The following is a description of a gene set: Abnormal upper limb bone morphology studied in species Homo sapiens Human Gene Set: HP_ABNORMAL_UPPER_LIMB_BONE_MORPHOLOGY, and this is the list of marker genes: CLIP2, BRIP1, TRPV4, AGPS, FGF10, FBXO11, TBX5, BRAF, PCYT1A, RRAS, COL1A1, RFWD3, CCNQ, ATL3, TNFRSF11A, KAT6B, LZTR1, GPX4, CSPP1 (centrosome and spindle pole associated protein 1), H3-3B, MAN2C1, RASA2, RUNX2, ASAH1, SKI, RSPO2, CLCN7, IFT52, SMAD6, FMR1, RPS19, AMMECR1, KRAS, B3GALT6, GNAS-AS1, TPM2, EOGT, COLEC11, HS2ST1, FLNB, MACROH2A1, EP300, PACS1, DHODH, CHST3, COL5A1, SNRPB, DNAJC30, MEIS2, CPLX1, MKKS, APC, AFF4, COL3A1, IFIH1, MED12, KIAA0753 (KIAA0753), LAMA5, WDR19, SUZ12, MAP2K2, ALG12, BAZ1B, SVBP, DYNC2H1, KIF7, SIAH1, TRPM3, SETBP1, PRKD1, KCTD1, MAP3K7, PIK3CD, PPOX, TWIST1, EXTL3, GNPNAT1, CILK1, FANCM, PALB2, RAD21, DHX30, CLDN16, SLC39A13, RAB23, BMP6, NDN, POLR3A, ARHGAP31, SOS1, SLC26A2, MTX2, IFT140, POGZ, NALCN, PRG4, RLIM, TBL2 (transducin beta like 2), FAT4, PHYH, MMP14, ERCC4, HFE, BHLHA9, SNIP1, RAB3GAP2, CHRNG, MAFB, GLB1, TCTN3, MMP13, TNFRSF11B, TCF12, DNM1L, COG4, PCNT, RIPK4 (receptor interacting serine/threonine kinase 4), OFD1, LIG4, SNRPN, NHS, RRAS2, KIAA0586, ZIC3, RSPRY1, GLI3, EIF4A3, MEGF8, DVL3, CYP26B1, KCNJ2, EXOC6B, POR, KIF22, CPLANE1, PCDHGC4, EIF4H, SATB2, PTCH1, KNSTRN, FANCG, GATA4, USP9X, COL2A1, CHN1, SCN9A, NRAS, JAG1, DHCR7, DCHS1, SIL1, ARID1B, BANF1, STX1A, FZD2, G6PC3, TOMM7, BMPR1B (bone morphogenetic protein receptor type 1B), HOXA11, XYLT1, RFC2, ADAMTS10 (NCBI Gene Id 81794), EXOSC2, RBM10, MATN3, ANKRD55, TMEM270, FERMT1, PTPN2, GJA5, PDE3A, TBX15, FIG4, AGA, FGF16, CLCN3, RAF1, SRCAP, SALL4, MAP2K1, P3H1, SMARCA2, CSGALNACT1, HOXD13 (homeobox D13), MECOM, CTBP1, FANCE, ROBO1, BMPR1A, NFIX, STX16, SHH, LONP1, IFT80, COLEC10, COL11A2, BPTF, INPPL1, AFF3, GPC3, LRP5, COL10A1, ERI1, COL9A1, ZNF141, SF3B4, RIT1, PIGT, RBPJ, MTHFS, FANCC, TRPS1, RECQL4, DOCK6, PIGS, RERE, PDE4D, SHOX, FANCF, WNK1, VPS37D, RETREG1, COMP, GUSB, GNPTAB, OBSL1, FANCB, ROR2, SCARF2 (scavenger receptor class F member 2), TGFB1, PYCR2, RIGI, DNA2, BMP2, NCF1, ZIC1, CBFB, IFT81, RAD51, MMP2, TMEM67, SMC1A, HNRNPR, NEK1, PTEN, ZNF668, TGDS, EXT2, RPL26, SLX4, GPC6, HDAC8, SH3PXD2B, CD96, TMEM216, MAD2L2, SPRED2, PTHLH, NPR2, VAC14, GNAS, SUMF1, L1CAM, CWC27, ASXL2, COL5A2, UBE2T, CTSK, SMC3, KL, CDKL5, IFT122, HPGD, COL9A3, ATP7A, ERCC1, TBX22, SPARC, HOXA13, B3GLCT, FLNA, CCDC8, PUF60, IFT43, PQBP1, TAF6, LBR, KCNH1, CREBBP, ACVR1, LETM1, MLXIPL, ANAPC1, CHSY1, CUL7, BPNT2, MYSM1, CDC45, MEG3, COL27A1, MYL11, H3-3A, FAM149B1 (NCBI Gene Id 317662), RTL1, PTH1R, STAT4, IFT27, PRKAR1A, GTF2I, MMP9, BCOR (NCBI Gene Id 57686), TNNT3, SALL1, BRCA1, FGF23, TONSL, FANCA, PRMT7, FGFR1, LRP4, B3GAT3 (beta-1,3-glucuronyltransferase 3), COL9A2, CREB3L1, EXT1, FANCI, GATAD2B, SMOC1, XRCC2, TAPT1, DACT1, MRAS, BICRA, GALNS, ATR, ADNP, IL2RB, DNMT3A, CANT1, DONSON, GSC, HHAT, B4GALT7, LTBP3, TFE3, VPS13B, SMO, LIMK1, MSX2, ZMPSTE24, PITX1, SUCLG1, B2M, IHH, GTF2IRD2, ELN, PRKG2, RBM8A, CCN2, ESCO2, FKBP6, TRIO, METTL27, CBL, PLXND1, PEX7, EZH2, GJA8, PDGFRB, CD247, BRD4, COL11A1, DLK1, DYM, TMEM231, SAMD9, DDR2, EED, INTU, PORCN, WNT7A, GNPAT, BGN, IFITM5, GJB6, CTSC, DLL4, NOTCH2, TP63, NONO, NPR3, NXN, PTPN22, NOG, RNF13, LMX1B, PSMD12, TWIST2, VPS35L, PTDSS1, RPS6KA3, IL2RA, BUD23, LMNA, GDF5, DVL1, FBN1 (fibrillin 1), NSUN2, SOS2, RAB33B, MYH3, PIEZO2, WLS (NCBI Gene Id 79971), FBLN1, WNT5A, BMP1, BRCA2, FANCD2, SRY, LYSET, IFT56, KIF1A, NOTCH1, FANCL, TNNI2, NSD1, FGFR3, REV3L, SLC25A24 (solute carrier family 25 member 24), AKT1, ASXL1, FBXL3, FKBP10, RNU4ATAC, FGFR2, TBX3, PEX5 (NCBI Gene Id 5830), PTPN11, TOPORS, RAD51C (RAD51 paralog C), OTUD6B, PDE6D, GTF2IRD1, LMBR1, FGFRL1, POC1A, MASP1, MAGEL2, ALX4, MAF, NIPBL, CHD7, FGF9, HDAC4, TRIP11, NEPRO, SOX9, ADAMTSL2, SETD5, RMRP, GPC4, ACAN, NSD2